Given this list of marker genes Cxcl15, Htr2c, Arhgap29, Zc3h12c, Nae1, Wrn, Mapk1, Vldlr, Spdya, Zscan22, Ppig, Sec24d, Car8, Ube3c, Gata2, Zfp280d, Kcne1, Cep350, Sema6d, Zfp131, Marchf6, Maco1, Uqcc4, Pou2f1, Apc, Tktl2, Adnp, Klhl32, Selenoi, Mageb4, Morc2a (microrchidia 2A), Or5m3b, Hcfc1, Lims1, Kdm2a, Usp27x, Plppr4, Slc24a2, Pclaf, Syf2, Ints6l, Fam149a, Elavl2, Scamp2, Mafk, Smg1, Tnfsf11, Slc6a8, Nefl, Zfc3h1, Zfp451, Zranb2, Ntrk3, Gspt1, U2surp, Amn1, Ltb4r2, Npepps, Dcx, Pacc1, Egr4, Slc20a1, Mex3b, Pcdh9, Reps2, Ttc33, Fhl1, Atp6v1a, Gpr37, Sync, Clec14a, Zbtb18, Spry2, Shld2, Arhgef7, Tmem70, Hivep2, Snx4, Tnfrsf21, Creb1, Isca1, Nfkbia, Prrx1, Zfp654, Actc1, Ppip5k2, Marchf8, Raph1, Cstf2t, Usp34, Helt, Matn3, Bmp5, Sbno1, Bard1, Azin1 (antizyme inhibitor 1), Crispld2, Ncapg, Slc25a53, Usp12, Nat2, Ube2e1, Fndc3b, Syncrip, Arfgef2, Cpsf6, Unkl (NCBI Gene Id 74154), Cables1, Ppp1r1b, Arhgef5, Crebzf, Sh3kbp1, Tmem114, Zfp598, Vim, Rasal2, Ube2v1, Slc16a4 (solute carrier family 16 (monocarboxylic acid transporters), member 4), Dmxl1, Crkl, Ncoa7, Atad1, Hrh4, Ccp110, Hoxd1, Clk1, Slc12a2, Nfat5, Mtpn, Syt16, Birc6, Abtb3 (ankyrin repeat and BTB domain containing 3), Wdr1, Tceanc, Slitrk4, Shroom3, Atg4c, Clec4a4, Fyco1, Rbms1, Rsf1, Kif21a, Dlg3, B3gnt2, Tmem131, Elavl4, Rtl4, Elf3, Tmem134, Corin, Sirt1, here is a description of the gene set: from publication Chen Y, Wang X (PMID 31504780) Mouse Gene Set: MIR_7025_3P studied in species Mus musculus Genes predicted to be targets of miRBase v22 microRNA mmu_miR_7025_3p in miRDB v6.0 with MirTarget v4 prediction scores > 80 (high confidence targets).